Given this list of marker genes THRSP, GALNT11 (polypeptide N-acetylgalactosaminyltransferase 11), ZNF521, ITGAV, NCAPD2, C1orf54, CAPN6, ETFDH, KRT16, TNNT2, DCUN1D1, LRRC8C, PECAM1 (platelet and endothelial cell adhesion molecule 1), XRN2, KPNA6, CMTR1, AP3M1, CKM (creatine kinase, M-type), MAPRE2, ME1, AMD1, FGL2 (fibrinogen like 2), ZNF260, KRT77, NT5E, SLC6A4, ART3, TNFAIP6 (TNF alpha induced protein 6), SLC22A2, EIF4H, SLC11A2, CAV3, SLC48A1, ZIC3, LRG1, MRAP, LIPA, CLEC4E, MCM6 (minichromosome maintenance complex component 6), RGS4 (NCBI Gene Id 5999), RAB2B, PINK1, BBOX1, CFD, GPD1, PITX2, CTDSP2, SNRPN, ITGA4, CD36, SRGN, ARL5A, CAPZB, IL33, RAD21, TSHR, NLK, ASB6, B2M, FBLN1, CCL20, CALCOCO2, ZNF330, LANCL2, PFKFB3, SPON2, PDGFC, TMEM234, SOD3, TMEM191C, ZSCAN26, MRPL3, MAP1B, SLC39A3, RXRA, MARCHF2, SPRR2D, ARHGAP1, NCOA4, MEF2A, RECQL, RNF114, CLDN15, SERPINA12, FECH, UQCRB, RSAD2, TWSG1, AP2A1, MSRA, HBS1L, RPS25, SPRR1B, DRAM1, RANBP9, BTC, KLF3, RRM1 (ribonucleotide reductase catalytic subunit M1), PTBP3, SH3KBP1, ABCB8, AK3, EPHA5, CPT1B, EPS8L1, MAP2, CLNS1A, TNNI1, HAS3, VAPB, ATP2A1, PSMF1, GIT2 (NCBI Gene Id 9815), NABP1, AKR1B10, SOX4, BZW1, MS4A6A, TUBGCP2, SDCBP2, CD74, ILF3, SORT1, ATXN7L3B, WARS1, RETN, RBMS1, NDUFS4, KRTDAP, ATPAF2, SNRNP27, NEU2, NCF2, CHCHD10, PIP4K2A, RGCC, LANCL1, PCYT1A, EIF4G1, CA3, PTGS2, STOM, PRDX1, RBM6, QPCT, ALOX5AP, TNFRSF19, CLDN5, UBB, SLC25A10, ADH1A, MFAP5, LGALS9, NNAT (neuronatin), PNPLA2, CDKN1C, PRPS1, IL36G, DVL1, CD163, HCFC1, ACTA1, GLRX (glutaredoxin), DGCR2, OS9, HIPK3, IL36RN, CCT6A, SERP1 (NCBI Gene Id 27230), DUSP1, CCL15, NEDD4, GJA1, UBE2D3, LGALS1, PUM1, ATF2, MGAT2, CENPB, AIF1L, KRAS, UCP3, CLCF1, BPHL, IL6ST, KLHL13, SERPINB2, SPON1, LCP1, LITAF, CLDN10, GBP2, TNFSF14, DNPEP, MAGOHB, HSPB7, LDHC, HLA-B, KDM8, NUDT7, RNF14 (NCBI Gene Id 9604), ADD3, PIGO, TSLP, AGPAT5, TYROBP, TRIB1, ITIH5, PRELP, GET3, HDC, PTPN14, PJA1, BICD2, NTN1, LPL, TMEM106C (NCBI Gene Id 79022), ACKR1, SREK1, CHRND, GNAS, ESYT3, CAT, OSR2, OPA1, IFI27L2, ROPN1L, SUCO, MRC2, QSOX1 (quiescin sulfhydryl oxidase 1), MAN1A2, UCK1, TCEA1, PDE4DIP, CHPT1, SLC26A7, BCL2L13, SERPINB1, PIP5K1A, COX6A1, PON3, IMMT (NCBI Gene Id 10989, inner membrane mitochondrial protein), ITGA9, TXNDC12, EIF3A, PTGFR, SORBS1, RARRES2, LY6D, KIF11, PROKR1, APOC2, PCK1, IER3, FCGR2B, CYSRT1, HDLBP, PCSK6, RBP7, H1-2, FUCA1, ITM2A, SERPINB9, CCN3, TGFBR2, PRR13, TFPI2, IFT46, PRKCE, PILRA, HIF3A, ACSL1, CASQ1, CAPRIN1, NAP1L1, HAVCR2, NPY4R, NUBP1 (NUBP iron-sulfur cluster assembly factor 1, cytosolic), EREG, PSME4, INPPL1, GNA12, ANGPTL2, SEPTIN8, RPA1, ACTB, NDUFAF7, CCNL2, CNOT4, COL4A5, BID, PAPOLA, RAB31, CDKN1A, KIF20A, MYO5B, MSR1, DDX3X, FADS2, DRAM2, CTBS, ZNF106, FAM162A, WDR48, ERI2, MYL4, DNM2, GHR, PRMT6, SREK1IP1, CFL2, TGFBR3, DCTN4, RILPL2, CXCL12, YKT6, LMBR1, WDR45, SMOC2, ACAD8, PRKACB, TSPAN3, IL18R1, SCUBE1, PITPNB, MTX1, TIA1, HOXB2, KRT6B, PBK, TPSD1, ZMYM4, IGHG1, BAG4, ACO1, MYL1, CTR9, TM6SF1, IP6K1, TCF7, PLGRKT, TMEM45A, BMP1, JAK1, PPP3CA, SEC61A2 (SEC61 translocon subunit alpha 2), GZMH (NCBI Gene Id 90562), ARRDC4, CFAP97 (cilia and flagella associated protein 97), SPTBN1 (spectrin beta, non-erythrocytic 1), PSAP, WEE1 (WEE1 G2 checkpoint kinase), LBP, SKP2, CENPV, GRB10, HMGCS2, TPP2, CPD, SPIN1, HADH, SLC2A4, TPSB2, HCAR2, APOA4, BNIP3, NSF, SLC4A10, ENPP3, AGK, TGFBI, PLD1, ZBED3, HACD3, LMAN1, LTBP1, TGFB2, DDX3Y, TRIP13, GPSM1, CEP85, S100A8, TMEM106B, GLO1, GZMB, CAMK4, ZFR (zinc finger RNA binding protein), PRKD3, RPGRIP1, BCAP31, AGTR2, SLC25A13, SNX17, USF1, LAMA2, MOB1A, ASPH, UBAP2L, ATF3, SCOC, DUSP22 (NCBI Gene Id 56940), HMGA2, ACBD3, NR4A1, ETFRF1, ACOX1, CYP11A1 (cytochrome P450 family 11 subfamily A member 1), FTH1, SELENOF, ZC3H11A, ZFP37, SOX11, RAMP2, TMED9 (transmembrane p24 trafficking protein 9), TNNC1, PC, NPM3, FUT2, LASP1, RTN4, WASHC2C, TMEM222, ADD1, TP63, LIPE, SIGMAR1, C4orf3, HBP1, TP53INP2, ALAS1, RACGAP1, BRAT1, SIRPA, RXYLT1, SGPL1, AHR, FERMT3, TIMMDC1, MISP, CA4, SRPK1, LILRB1, GSTA2, SIX2, CCN1, SET, LXN, GSTZ1, FAM107B, C5orf15, INTS12, NCOA5, TRBC2, TMEM109, S100B, TM6SF2, CD44, KLK1, USP34, CYP4B1, LAPTM4A, TXNIP, RPTN, FNTA, CASP6, SLC25A48, BAD, MIR214, FBP2, HNRNPLL (heterogeneous nuclear ribonucleoprotein L like), ARCN1, SGCG, CACNA2D1, ELOC, COA5, IDH3G, SERPINB4, RBBP4, KLB, AP2B1, RRN3, SERPINF1, RIMOC1 (RAB7A interacting MON1-CCZ1 complex subunit 1), RNF41, EMP2, CMA1 (NCBI Gene Id 1215), PEG3, NADK (NAD kinase), TREX2, ARPP19, ACTC1 (actin alpha cardiac muscle 1), DYNLT1, FBXW8, CA13, CAB39L, C1QB, RFC1, SCD, GOSR2, IL1R2, LIMS1, ACYP1, FOS, TRIAP1, PTPRF, CXCL14, SERINC3, IFI16, CARS1, ACAA2, PDGFA, HOXB6, IKZF1, TMCC2, PLA2G2F, DHX40, SMAD5, FBLN2, PCCA, BABAM2, CLCA3P, TCAP, LYZ, TFRC, RABGAP1, SPAG5, RDH10, PTTG1, AQP1, CPA3, PLAC1, STAR (steroidogenic acute regulatory protein), LCE1B, VN1R17P, ABCC5, FABP1, MR1, LMNB1, PMEPA1, SLC35A3, MORC3, NSMAF, DTX3, CCND2, CCDC71, PEX13, CELF2, SLC22A5, ART1, PDLIM5, IL36A, SPPL2B, GNA13, NDRG1, PRKAR1B, CEACAM1, IDE, CHD9, ZNF445, RAB40C, DNAJB1, IL2RG, DPYSL3, CP, TCIM, CTTN (cortactin), POU2F3, HOXA9, ZNF410 (zinc finger protein 410), CDC42BPA, ALDH1A1, FSCN1, TF, APP, USHBP1, THBS1, FAH, AVPR1A, TCF12, DLK1, PEA15, LUM, STARD4, LTC4S, PTPRZ1, NDST2, FGFR2, IMMP2L, TBK1 (NCBI Gene Id 29110), ESD, EML5, TBRG4, CIDEC, NR3C1, GINM1, SWSAP1 (SWIM-type zinc finger 7 associated protein 1), UBE2H, UCP1, CLDN11, ASB7, SLC14A1, NCF1, TCEAL3, CSRP3 (NCBI Gene Id 8048), CCDC43, NSUN4, ST3GAL2 (NCBI Gene Id 729518), SAR1A, CD59, CTF1, PTPRG, CUX1, SLC45A3, PLEK2, IGF2, PDPK1, HLA-DQA2, SNCG, HSPA9, CAV2, ZNF574, NIT2, here is a description of the gene set: Human Gene Set: MARTINEZ_TP53_TARGETS_UP studied in species Mus musculus from publication Martínez-Cruz AB, Santos M, Lara MF, Segrelles C, Ruiz S, Moral M, Lorz C, García-Escudero R, Paramio JM (PMID 18245467) Genes up-regulated in mice with skin specific knockout of TP53. Squamous cell carcinomas (SCC) represent the most aggressive type of nonmelanoma skin cancer. Although little is known about the causal alterations of SCCs, in organ-transplanted patients the E7 and E6 oncogenes of human papillomavirus, targeting the p53- and pRb-dependent pathways, have been widely involved. Here, we report the functional consequences of the simultaneous elimination of Trp53 and retinoblastoma (Rb) genes in epidermis using Cre-loxP system. Loss of p53, but not pRb, produces spontaneous tumor development, indicating that p53 is the predominant tumor suppressor acting in mouse epidermis. Although the simultaneous inactivation of pRb and p53 does not aggravate the phenotype observed in Rb-deficient epidermis in terms of proliferation and/or differentiation, spontaneous SCC development is severely accelerated in doubly deficient mice. The tumors are aggressive and undifferentiated and display a hair follicle origin. Detailed analysis indicates that the acceleration is mediated by premature activation of the epidermal growth factor receptor/Akt pathway, resulting in increased proliferation in normal and dysplastic hair follicles and augmented tumor angiogenesis. The molecular characteristics of this model provide valuable tools to understand epidermal tumor formation and may ultimately contribute to the development of therapies for the treatment of aggressive squamous cancer.